The following is a description of a gene set: Any process that modulates the frequency, rate or extent of DNA recombination, a DNA metabolic process in which a new genotype is formed by reassortment of genes resulting in gene combinations different from those that were present in the parents. Mouse Gene Set: GOBP_REGULATION_OF_DNA_RECOMBINATION species: Mus musculus, and this is the list of marker genes: Ing3, H1f10, Terf2, H1f3, Il2, Helq, Smarcad1, Mrgbp, Supt6, H1f0, Klhl15, Atad5, Mlh1 (mutL homolog 1), Cd40, Parp1, Pot1b, Ercc2, Arid2, Rad51ap1, Fbh1, Was, Dmap1, Crebbp, Mir181b-1, Trrap, Spidr, Ooep, Csnk2a1 (casein kinase 2, alpha 1 polypeptide), H1f2, Morf4l1, Shld3, Kmt5a, Vps72, Setd2, Kmt5b, Sirt6, Pias4, Parpbp, Actb, Il27ra, Pagr1a, Hmces, Cd28, Pms2, C1qbp (NCBI Gene Id 28127), Peli1, Cgas, Skp2, Fancb, Rmi2, Parp3 (NCBI Gene Id 320721), Blm, Prdm9, Ppp4r2, Timeless, Stat6, Tgfb1, Mrnip, Rnf8, Usp51, Mad2l2, BC037156, H1f9, Rtel1, Actl6a, Zcwpw1, Ptprc, Zfp365, Paxip1, Hdgfl2, Ndfip1, Ruvbl1, Epc1, Plk1, Ppp4c, Rad50, Ankle1, Wdr48, Zranb3, Exosc3 (exosome component 3), Msh6, Ubqln4, Kmt5c, Tex15, Tnfsf13, Tbx21, Ercc6, Rpa2, Il4, Mir181b-2, Epc2, Exosc6, Msh2, Actr2, Tnfsf4, Helb (helicase (DNA) B), Ifng, Polq, Shld1, Yeats4, Clcf1, H1f5, Terf2ip (NCBI Gene Id 57427), Ruvbl2, Morf4l2, H1f8, Ube2b, Fignl1, Msh3, Abl1, Senp3, Khdc3, Kat5, Zscan4c, Smchd1 (SMC hinge domain containing 1), Rif1, Mbtd1, Trp53bp1, Recql5, H1f6, Radx, Aplf, Fus, Bcl6, H1f4, H1f1, Prmt1, Brd8, Rad18, Nsd2, Wrap53, Meaf6, Kdm1a, Tfrc, Rnf126, Chek1, Shld2, Rad51, Slc15a4, Foxp3, Ep400, Lig3